Given this list of marker genes GRB2, BCAR3, SOCS3, PLCG2, LCK, VAV2, HCK, SH3BP2, SHD, SHC1, CRK, SAMSN1 (SAM domain, SH3 domain and nuclear localization signals 1), PFN1, CBLB, CRKL, PTPN5, SHE, SH2D3C, YES1, CBL, PIK3R3, SH2D3A, STAP1, PTPN11, MAPK1, CBLC, SHC3, MAPK3, ABL2, GRAP2, ZAP70, ABL1, GRAP, VAV1, SLA (NCBI Gene Id 6503), SHF, FGR, PTPN3, LDLRAP1, IRS1, PIK3R1, SHB, PTPN6, RASA1, SYK, PIK3R2, NCK2, here is a description of the gene set: Binding to a phosphorylated tyrosine residue within a protein. Human Gene Set: GOMF_PHOSPHOTYROSINE_RESIDUE_BINDING species: Homo sapiens